Given this list of marker genes GP2, ZNF682, LINC00216, DYNC2I1, SLC26A2, SUB1, PRPF8 (NCBI Gene Id 6108), RAB11FIP1, HPSE2, GCM2, TRHR, MTOR, HOPX (HOP homeobox), TPP1, LYN, LRP4, PMS2P11 (PMS1 homolog 2, mismatch repair system component pseudogene 11, NCBI Gene Id 107161145), TGM5, CFHR5, NTF3 (neurotrophin 3), SEPTIN7P11, ZNF155, ELAPOR1, GBE1, SLC7A11, KCNS3 (potassium voltage-gated channel modifier subfamily S member 3), AKR1D1, RPS6KA4, CAMK1G, ERC2-IT1 (NCBI Gene Id 711), ADCYAP1, GEMIN2, MAST4, SIT1, RCN1, KIF4A, RUNDC3B, ZNF80, BCL2, SYBU, WASF1, AQP3, CES1P1, PTTG1, NECTIN2, ADAM7, MARCHF3, TFAP4, FKBP1A, TOGARAM1 (NCBI Gene Id 23116), UBQLN3, ASMTL-AS1, DCUN1D4, SLC25A22, ZMIZ2, PLA2G4C, PGAP6, ENSG00000284948, TRAV12-2, SNRPC, CCR7, ASAP1, TYW1, BTG3, SLC16A1, EMC9, CCDC92 (NCBI Gene Id 80212), PLA2G7 (NCBI Gene Id 7941), MTG1, ZNF37BP, RAB14 (NCBI Gene Id 51730), ENPP2, NRP1, SNAP91, NCAM2, MAL, KRT86, CHP2, PCIF1, SPICE1, TMEM106C, GRIN1, TBL3, XPO6, RXFP3, GGH, TSFM, CCR10, PAX6 (paired box 6), SSTR2, C1orf21 (NCBI Gene Id 81563), TRIM58, SLC38A6 (solute carrier family 38 member 6), GPD1, KANK1, SSR1, PRKD1, GFPT2, MT1M, KIAA0040, FARP2, PRDM5, TBR1, EHD3, NR1H2, ULBP1, ATP4A, ABCA6, ARNT, FBXL15, ANKRD36BP2, DRD4, STUB1, IFNG, SMAD6, PFN2, IGF2BP3, PPARG, SNX1, LAMP5, INPP5E, MEAK7, TARBP2, HAPSTR1, SH2D4A, TESK2, TXNL4B, GNG12, RASGRP3, MAP3K9, XPO4 (exportin 4), CNMD, CRYAB, MID2, ZFX, NFYA, ZNF821, STC2, SLC29A1, OPRM1 (opioid receptor mu 1), PTGER3 (NCBI Gene Id 5733), IFIT2, RNF186, TRAF5, DKK1, SNRNP35, C2orf68, SLC25A24, RLBP1, DTNA, RUNX1T1, MC1R, PKIA, GSDMD, NUBP2, DEFB126, LGALS3BP, TMEM158, CABYR, MFSD6, EOLA2-DT, THAP7, ANKRD7, TCEAL2, SHARPIN, SCARA3, KLHL41, PSEN2, TRIM31, GHR (NCBI Gene Id 2690), ZNF239, EP400, MAP7, ADAM12, B9D2, SNTG1, PLIN2, CST4, SCGB1D1, SP140, PDCD2, ABAT, GALNT3, DHCR7, STRA6, AIRIM, DCTN4, AOC3, FCGR1BP, PFKFB2, AMZ2, ADIPOQ, ERI2, PARP16, HYOU1, TENM1, CDH22, here is a description of the gene set: Systems vaccinology has emerged as an interdisciplinary field that combines systems wide measurements and network and predictive modeling applied to vaccinology. Here we used the systems vaccinology approach to study the molecular mechanisms underlying th Genes up-regulated in comparison of myeloid dendritic cells (mDC) from LAIV influenza vaccinee pre-vaccination versus those at day 7 post-vaccination. from publication Nakaya HI, Wrammert J, Lee EK, Racioppi L, Marie-Kunze S, Haining WN, Means AR, Kasturi SP, Khan N, Li GM, McCausland M, Kanchan V, Kokko KE, Li S, Elbein R, Mehta AK, Aderem A, Subbarao K, Ahmed R, Pulendran B (PMID 21743478) Human Gene Set: GSE29618_PRE_VS_DAY7_POST_LAIV_FLU_VACCINE_MDC_UP species: Homo sapiens